The following is a description of a gene set: Nasal congestion Reduced ability to pass air through the nasal cavity often leading to mouth breathing. Human Gene Set: HP_NASAL_CONGESTION species: Homo sapiens, and this is the list of marker genes: NME5, CCNO, DNAL1, CCDC39, NEK10, RSPH1, DNAAF2, SPEF2, LRRC56, ARSL, FGFR1, GNAS, DNAH1 (dynein axonemal heavy chain 1), TTC12, ODAD4 (outer dynein arm docking complex subunit 4), GJA1, DNAAF3, RSPH4A, DBH, DNAAF1 (dynein axonemal assembly factor 1), ANKH, CCDC40, CPT2, DNAH9, ODAD3, DNAJB13, CARMIL2, ZMYND10, ODAD2, DNAAF11, ODAD1, CFAP74 (cilia and flagella associated protein 74), DNAH11, NME8, RSPH3, DNAAF4, CFAP300, PIK3CG, STK36, HYDIN, FOXJ1, DRC1, ARL2BP, RSPH9, RPGR, GAS2L2, CFAP298, DNAAF6, DNAAF5, CFAP221, MCIDAS, DNAI2, DDC, DNAI1, DNAH5, OFD1, SPAG1